The following is a description of a gene set: species: Homo sapiens Human Gene Set: GOMF_SYMPORTER_ACTIVITY Enables the active transport of a solute across a membrane by a mechanism whereby two or more species are transported together in the same direction in a tightly coupled process not directly linked to a form of energy other than chemiosmotic energy., and this is the list of marker genes: SLC17A6, SLC15A2 (solute carrier family 15 member 2), SLC1A6, SLC39A6, SLC12A7, SLC16A4, SLC6A18, SLC12A9, SLC16A3, SLC6A12, SLC1A2, SLC6A7, SLC10A2, MFSD2A, SLC12A8, SLC45A1, SLC36A4, SLC13A5, SLC15A3, SLC24A2, SLC16A13, SLC28A2, SLC16A11, SLC13A3 (solute carrier family 13 member 3), SLC5A3, SLC38A2, SLC18A1, SLC34A1, SLC4A9, SLC17A3, MFSD12, SLC5A8, SLC6A13, SLC22A18, SLC32A1, SLC6A15, SLC16A14, SLC17A8, SLC6A1, SLC6A4, SLC6A11, SLC38A4, SLC6A5, SLC12A3, SLC10A6, SLC13A4, SLC25A18, SLC12A6, SLC46A3, SLC15A5, SLC5A5, SLC1A7, SLC4A4, SLC23A1, SLC2A13, SLC24A3, SLC36A2, SLC39A12, SLC4A7, SLC23A2, SLC1A3, MFSD2B, SLC28A3, SLC22A5, SLC17A2, SLC6A19, SLC16A9, SLC11A2, SLC10A4, SLC34A3, SLC17A5, SLC10A7, SLC10A1, SLC2A10, SLC5A6, SLC1A1, SLC10A5, SLC1A5, SLC34A2, SLC24A1, SLC25A3, SLC17A4, SLC4A10, SLC39A8, SLC5A2, SLC5A1, SLC38A1, SLC46A1, SLC5A4, MFSD4B, SLC13A1, SLC6A14, SLC38A7, SLC45A2, SLC6A9, SLC36A3, SLC22A4, SLC6A2, SLC6A6, SLC5A9, SLC5A11, SLC17A1, SLC4A8 (NCBI Gene Id 9498, solute carrier family 4 member 8), SLC12A2, SLC10A3, SLC4A11, SLC15A1, SLC39A4, SLC39A5, SLC6A16, SLC46A2, SLC16A1, SLC12A5, SLC25A22, SLC16A5, SLC6A3, SLC16A7, SLC6A17, SLC39A10, SLC28A1, SLC36A1, SLC17A7, SLC13A2, SLC4A5, SLC20A2, SLC24A4, SLC6A20, SLC5A12, SLC18A2, SLC5A7, SLC45A3, SLC1A4, SLC39A14, SLC29A1, SLC45A4, SLC2A9, SLC38A3, SLC16A8, SLC6A8 (solute carrier family 6 member 8), SLC12A1, SLC20A1, CTNS, SLC12A4, SLC22A1, SLC15A4, SLC24A5, SLC5A10